Given this list of marker genes POR, FGFR2, FGF9, TBX15, CYP26B1, DONSON (DNA replication fork stabilization factor DONSON), FGFR1, GDF5, NOG, WNT7A, PTDSS1, here is a description of the gene set: Human Gene Set: HP_HUMERORADIAL_SYNOSTOSIS studied in species Homo sapiens An abnormal osseous union (fusion) between the radius and the humerus. Humeroradial synostosis